Given this list of marker genes Jun, Btg2, Junb, Tsc22d3, Ddit4, Hspa1a, Uba52, Hspa1b, here is a description of the gene set: Cytokines mediate cell-cell communication in the immune system and represent important therapeutic targets. A myriad of studies have highlighted their central role in immune function, yet we lack a global view of the cellular responses of each immune cell type to each cytokine. To address this gap, the authors created the Immune Dictionary, a compendium of single-cell transcriptomic profiles of more than 17 immune cell types in response to each of 86 cytokines (>1,400 cytokine-cell type combinations) in mouse lymph nodes in vivo. A cytokine-centric view of the dictionary revealed that most cytokines induce highly cell-type-specific responses. For example, the inflammatory cytokine interleukin-1β induces distinct gene programmes in almost every cell type. A cell-type-centric view of the dictionary identified more than 66 cytokine-driven cellular polarization states across immune cell types, including previously uncharacterized states such as an interleukin-18-induced polyfunctional natural killer cell state. from publication Cui A, Huang T, Li S, Ma A, Pérez JL, Sander C, Keskin DB, Wu CJ, Fraenkel E, Hacohen N (PMID 38057668) Genes negatively differentially expressed in cell type: CD4+ T cell upon treatment with cytokine: IL-36Ra in mouse lymph nodes in vivo. species: Mus musculus Mouse Gene Set: CUI_T_CELL_CD4_IL36RA_RESPONSE_DN